Given this list of marker genes AP3S1, AP3S2, AP3B2, AP3M2, AP3B1, AP3D1, AP3M1, here is a description of the gene set: Human Gene Set: GOBP_CLATHRIN_COATED_VESICLE_CARGO_LOADING studied in species Homo sapiens Formation of a macromolecular complex between the cytoplasmic coat proteins on clathrin-coated vesicles and proteins and/or lipoproteins that are going to be transported by a vesicle.